The following is a description of a gene set: electronically inferred by orthology from the curated human pathway Reactome Pathway: Hyaluronan metabolism This event has been computationally inferred from an event that has been demonstrated in another species.<p>The inference is based on the homology mapping from PANTHER. Briefly, reactions for which all involved PhysicalEntities (in input, output and catalyst) have a mapped orthologue/paralogue (for complexes at least 75% of components must have a mapping) are inferred to the other species. part of: Glycosaminoglycan metabolism studied in species Mus musculus, and this is the list of marker genes: Hyal2, Hyal1, Hyal4, Hexa, Stab2, Slc9a1, Hexb, Hyal5, Has1, Hmmr